The following is a description of a gene set: The chemical reactions and pathways resulting in the breakdown of a nucleoside phosphate. Human Gene Set: GOBP_NUCLEOSIDE_PHOSPHATE_CATABOLIC_PROCESS studied in species Homo sapiens, and this is the list of marker genes: ENO4, OGDHL, NUDT4, PRTFDC1, ENO2, SLC4A4, NT5C1A, NUDT10, PRKAG2, ARNT (aryl hydrocarbon receptor nuclear translocator), SUCLG1, HK3, ENTPD4 (NCBI Gene Id 9583), PGM1, SAMHD1, MLST8, PFKFB2, AMPD3, NT5C, PRKACA, GCK, PSEN1, TPI1, NT5M, NT5C2, FOXK2, SMPDL3A, GAPDH, TYMP, OGG1, GDA, P2RX7, ALDOC (NCBI Gene Id 230), GSK3A, IGF1, SLC4A1, ALDOA, PFKFB1, KAT2B, FOXK1, DNPH1, PGK2, PDE8B, PGAM2, COL6A1, DPYD, NCOR1, ARL2, ENTPD1, PFKFB3, ENTPD7, FITM2, INSR, UPB1, PGK1, UCP2, UPP1, PPARA, RPTOR, HTR2A, SUCLG2, FBP1, CBFA2T3 (CBFA2/RUNX1 partner transcriptional co-repressor 3), PDE4D, ABCD1, ENTPD8, ENPP3, ADPGK, NUDT9, FHIT, PDE4B, XDH (NCBI Gene Id 7498), DUT, ENO3, TREX1, FLCN, NEIL2, LDHA, ENTPD5, UPP2, MTOR, ZBTB20, DERA, NUDT13, ZBTB7A, PKLR (pyruvate kinase L/R), EIF6, MBD4, NUDT18, EP300, PRKAA1, HPRT1 (hypoxanthine phosphoribosyltransferase 1), PDE2A, DCTPP1, NUDT4B, PNP, PGAM4, PDE5A, SLC2A6, BPGM, NUDT17 (NCBI Gene Id 200035), PDE4C, ADA, DHTKD1, MTCH2, CNP, NT5E, ACTN3, SIRT6, PDE7B (phosphodiesterase 7B), PDE7A, SMUG1, UNG, HK1, NUDT7, GPI, ACOT7, NT5C1B, STAT3, PFKL, SRC, GPD1, NUDT5, TRIM63, HKDC1, IFNG, DDIT4, ENTPD2, PRKAG3, GAPDHS, PRKAG1 (protein kinase AMP-activated non-catalytic subunit gamma 1), NTHL1, GIT1, INS, PFKM, BCL2L13, HIF1A, OGT, NUPR1, PDE10A, TDG, SUCLA2, JMJD8, IER3, NUDT19, PFKP, ENTPD3, NUDT15, ALDOB, PRKAA2, OGDH, GALK1, MLXIPL, PDE4A, SARM1, MLYCD, HINT1, VNN1 (NCBI Gene Id 8876), PPP2CA, FKRP, NUDT12, NEIL1, PGAM1, PDE8A, ENPP1 (NCBI Gene Id 5167), UCHL1, ENO1, PDE9A, VCP, MFSD8, ACAT1, HK2, APP, DPYS, PDE1A, NUDT11, PRXL2C, NUDT8, PKM, MGAT1, HDAC4, NUDT16, LIPA, NUDT3, TIGAR, ITPA